The following is a description of a gene set: species: Mus musculus from publication Zheng Y, Josefowicz SZ, Kas A, Chu TT, Gavin MA, Rudensky AY (PMID 17237761) Genes with promoters bound by FOXP3 and which are up-regulated both in developing (located in the thymus) and mature (from peripheral blood) regulatory CD4+ T lymphocytes. Mouse Gene Set: ZHENG_FOXP3_TARGETS_UP Transcription factor Foxp3 (forkhead box P3), restricted in its expression to a specialized regulatory CD4+ T-cell subset (T(R)) with a dedicated suppressor function, controls T(R) lineage development. In humans and mice, Foxp3 deficiency results in a paucity of T(R) cells and a fatal breach in immunological tolerance, causing highly aggressive multi-organ autoimmune pathology. Here, through genome-wide analysis combining chromatin immunoprecipitation with mouse genome tiling array profiling, we identify Foxp3 binding regions for approximately genes and for an intergenically encoded microRNA. We find that a large number of Foxp3-bound genes are up- or downregulated in Foxp3+ T cells, suggesting that Foxp3 acts as both a transcriptional activator and repressor. Foxp3-mediated regulation unique to the thymus affects, among others, genes encoding nuclear factors that control gene expression and chromatin remodelling. In contrast, Foxp3 target genes shared by the thymic and peripheral T(R) cells encode primarily plasma membrane proteins, as well as cell signalling proteins. Together, our studies suggest that distinct transcriptional sub-programmes implemented by Foxp3 establish T(R) lineage during differentiation and its proliferative and functional competence in the periphery., and this is the list of marker genes: Snx9, Map3k8, Crem, Ikzf2, Nrp1, Prdm1, Icos, Ctla4, P4ha1, Il2ra, Cobll1, Eef1akmt1, Rhoh, Arl6, Lrrc8c, Abcb1a, Tent5c, Ifngr1, Frmd4b, Fam107b, Snx14, Cd44, Prkch, Cdc42se2, Ubash3b, Irf6